Given this list of marker genes St6galnac4, St6galnac3, Muc20, St3gal4, Muc13, Muc5b, St3gal2, Muc15, St6galnac2, Muc1, St3gal3, Muc17, here is a description of the gene set: Reactome Pathway: Termination of O-glycan biosynthesis studied in species Mus musculus This event has been computationally inferred from an event that has been demonstrated in another species.<p>The inference is based on the homology mapping from PANTHER. Briefly, reactions for which all involved PhysicalEntities (in input, output and catalyst) have a mapped orthologue/paralogue (for complexes at least 75% of components must have a mapping) are inferred to the other species. part of: O-linked glycosylation of mucins electronically inferred by orthology from the curated human pathway